The following is a description of a gene set: PTEN Regulation species: Mus musculus Mouse Gene Set: REACTOME_PTEN_REGULATION, and this is the list of marker genes: Lamtor2, Chd3, Akt2 (thymoma viral proto-oncogene 2), Psmd8, Psmd12, Psmc3, Csnk2b, Psmd1, Rps27a, Psmb4, Maf1, Chd4, Stub1, Csnk2a1, Psmb3, Uba52, Nedd4, Mta1, Psmd13, Mta2, Psma2, Csnk2a2, Pten, Akt3, Psmb6, Psmd6, Rnf146, Rragc, Psma3, Hdac1, Psma5, Usp13, Sall4 (spalt like transcription factor 4), Gatad2a, Mbd3, Ubc, Mta3, Uba52rt (NCBI Gene Id 676687), Psmd14, Frk, Ubb, Psmc4, Rheb, Mlst8, Rptor, Rraga, Psma6, Psmc2, Otud3, Akt1, Rbbp4, Psmd11, Psmd2, Psmc1, Psma4, Rragd, Prex2 (phosphatidylinositol-3,4,5-trisphosphate-dependent Rac exchange factor 2), Psma7, Psmb1, Psmb5, Psmc6, Pml, Slc38a9, Lamtor3, Psmb2, Rbbp7, Trim27, Gatad2b, Lamtor4 (late endosomal/lysosomal adaptor, MAPK and MTOR activator 4), Psmd3, Wwp2, Xiap, Lamtor5, Tnks, Psmc5, Rragb, Mtor, Tnks2, Lamtor1, Mkrn1, Psma1, Psmd7, Usp7, Adrm1, Psmb7